Given this list of marker genes MGP, COL4A2, BGN, CCN2 (cellular communication network factor 2), NNMT, ACTA2, PRSS23, SPARCL1, COL4A1, CCDC80, TIMP1, TIMP3, POSTN, MYL9, TPM2, COL6A1, LUM, TGFBI, RARRES2, CALD1, DCN, IGFBP7, A2M, CAV1, C1R, VIM, FBLN1, SNAI2, FN1, COL6A2, SERPING1, CTSK, ID3, IGFBP5, TCF4, SPARC, COL1A1, MMP2, TAGLN (transgelin), COL1A2, CCN1, TPM1, C1S, IGFBP4, COL6A3, TSC22D3, COL3A1, CXCL12, LGALS1, FSTL1, here is a description of the gene set: species: Homo sapiens Genes upregulated in subsets of cells of a given type within various tumors In this study, an extensive analysis was conducted to define meta-programs (MPs) capturing intra-tumor heterogeneity across a spectrum of tumor types. The approach utilized non-negative matrix factorization (NMF) to analyze each cell type separately within individual tumor samples. This involved the analysis of malignant cells, macrophages, fibroblasts, endothelial cells, epithelial cells, T-cells, and B-cells. NMF was executed with varying parameter values (K=4, 5, 6, 7, 8, 9), thereby generating 39 programs for each cell type per sample. Each NMF program was summarized by the top genes based on NMF coefficients.\nRobust MPs were then delineated for each cell type using a set of stringent criteria, including recurrence within the same tumor, similarity to programs in other tumors, and non-redundancy within a tumor. Subsequently, these robust NMF programs were clustered (per cell type) based on Jaccard similarity, leading to the identification of MPs associated with each cell type.\nTo enhance the quality of the MPs, a refinement steps were undertaken, involving the removal of MPs suspected of reflecting low-quality data (with an overrepresentation of ribosomal proteins or mitochondrial-encoded genes), single-study inclusion, or similarity to miss-annotated cell types. Human Gene Set: GAVISH_3CA_MALIGNANT_METAPROGRAM_12_EMT_1 from publication Gavish A, Tyler M, Greenwald AC, Hoefflin R, Simkin D, Tschernichovsky R, Galili Darnell N, Somech E, Barbolin C, Antman T, Kovarsky D, Barrett T, Gonzalez Castro LN, Halder D, Chanoch-Myers R, Laffy J, Mints M, Wider A, Tal R, Spitzer A, Hara T, Raitses-Gurevich M, Stossel C, Golan T, Tirosh A, Suvà ML, Puram SV, Tirosh I (PMID 37258682)